Given this list of marker genes Maf, Pik3ca, Gclm, Ephb2, Gclc, Gsta2, Aimp2, Nfe2l2 (nuclear factor, erythroid derived 2, like 2), Hmox1, Nqo1, Mapk8, Keap1, Cebpb, Prkca, here is a description of the gene set: Mouse Gene Set: WP_TRANSCRIPTIONAL_ACTIVATION_BY_NFE2L2_IN_RESPONSE_TO_PHYTOCHEMICALS Transcriptional activation by Nfe2l2 in response to phytochemicals studied in species Mus musculus